Given this list of marker genes CTNNBIP1 (NCBI Gene Id 56998), AMFR, CTHRC1, PRDM15, SOX2, CTDNEP1 (CTD nuclear envelope phosphatase 1), NOTCH1, CCNYL3, FZD10, BAMBI, SULF2, NPHP3, NPHP4, TBL1XR1, DRAXIN, GID8, RNF14, G3BP1, IGFBP6, UBE2B, SOX10, SFRP2, CTNNB1, NFKB1 (nuclear factor kappa B subunit 1), CHD8, PPM1N, MIR212, MIR1260B, DAAM2, LGR4, RBPJ, DKKL1, KPNA1, CCNYL1B, DVL3, FRAT1, TMEM198 (transmembrane protein 198), BMAL1, TLE7 (TLE family member 7), WNT6, MDK, NLE1, STK4, MIR1-1, AXIN2, TCF7L2, SHISA3, FZD7, TLE3, PPP1CA, LRRK2, JUP, RAB5A, CDH3, EDN1, CDK14, SDHAF2, MIR498, PPM1A, RUVBL2, TCF7, DAB2, WNT5A, PYGO1, WNT8A, SOX4, MAPK14, TTC21B, DISC1, WNT9A, TPBGL, VCP (valosin containing protein), SFRP5, EDNRA, WNT7B, TMEM88, APC, DDX3X, RBMS3, USP47, ZNRF3, TRPM4, BCL9L, TBL1X, NKD2, PRKN, GPC3, EGFR, SMAD4, MIR29B1, GPRC5B, GSKIP, MIR29C, CCNYL2, DLX5, FAM53B, BMP2, WNK2, EXT1, HHEX, LZTS2, IFT20, LRRK1, CCNYL1, RNF220 (ring finger protein 220), FZD4, SFRP4, FZD2, KLF4, CSNK1G3, INVS, DAB2IP, CTNND2 (NCBI Gene Id 1501), NDP, EGR1, DACT1, GLI1, NKX2-5, ZEB2, WNT10B, CDH2, CCNY, CSNK1E, SPIN4, MKS1, TLE2, BIRC8, BTRC, HESX1, UBAC2, NR4A2 (NCBI Gene Id 4929), NPPA, SBNO1 (NCBI Gene Id 55241), TLE1, NKD1, DACT3, APOE, FZD3, SCEL, GNAQ, EDNRB, WNT8B, SIAH1, CYLD, CSNK1G1, MIR665, MIR199A1, GREM1, RSPO1, IGFBP1, ASPM, FRZB, NHERF1, FGF2, TMEM88B, CBY1, CAPRIN2, PTPRO, NOG (NCBI Gene Id 9241), FOXD1, HECW1, WNT3A, LRP5, LIMD1, COL1A1, RUVBL1, CSNK1G2, PRICKLE1, FOXO1, WNK1 (WNK lysine deficient protein kinase 1), EGF, WWTR1, EMD, PFDN5, RARG, PPM1B, OTULIN, SFRP1, NOTUM, TCF7L1, FZD8, MIR501, ILK, SHH, SOST (NCBI Gene Id 8149), PTPRU, SOX9, IGFBP2, FZD5, FGF10, AMER3, USP34, TNKS, MCC, CAV1, WNT2B, PTK7, PSEN1, MIR203A, CSNK1A1, DKK4, CCDC88C, SHISA6, SOX13, AXIN1, FRAT2, FOLR1, GATA3, MIR26A1, RSPO3, TGFB1, RSPO4, TMEM196, FUZ, TLE4 (TLE family member 4, transcriptional corepressor), PYGO2, ADGRA2, MIR346, APC2, DVL1, SEMA5A, ADNP, WNT9B, SOSTDC1, FZD9, APP, POU5F1 (NCBI Gene Id 7934), FZD1, SMAD3, AMER1, SRC, TMEM131L (NCBI Gene Id 23240), RSPO2, FZD6, ZNF703, LGR6, PIN1, TLE5 (NCBI Gene Id 166), FRMD8P1, WNT5B, SIAH2, DAPK3, WNT16, WNT10A, GPC5, UBR5, LMBR1L, HDAC1, FERMT1, COL6A1 (collagen type VI alpha 1 chain), WNT1, LEF1, VPS35, USP8, PLEKHA4, IGFBP4, SMAD7 (SMAD family member 7), RPS12, WLS, DKK3, TBX18, MLLT3, EDA, WNT11, FGF9, WNT2, WNT4, LYPD6, FOXO3, SDC1, JRK, TMEM9, CSNK1A1L, LRP4, FRMD8, BICC1, ISL1, TNKS2, CCAR2 (cell cycle and apoptosis regulator 2), YAP1, OTUD5, AMER2, ZBED3, KREMEN1, DKK1, STK3, MIR145, JADE1, DIXDC1, TPBG, DDIT3, TMEM64, LATS1, RBX1, LATS2, MIR19B1, MAD2L2, GLI3, SCYL2, RECK, FGFR2 (NCBI Gene Id 2263), VPS4B, SMURF2, RNF146, STK11, NRARP, CSNK1D (NCBI Gene Id 1453), RYK, GSK3A, BCL9, LGR5, SOX17, WNT7A, LRP6, WNT3, XIAP, PPP2CA, PPP2R3A, KANK1, ATP6AP2, DVL2, TMEM170B, MESP1, ANKRD6, DKK2, SNAI1, TLE6, SNAI2, GSK3B, MIR183, here is a description of the gene set: species: Homo sapiens Human Gene Set: GOBP_CANONICAL_WNT_SIGNALING_PATHWAY A type of Wnt signaling pathway in which Wnt binding to its receptor on the surface of a target cell results in the by propagation of the molecular signals via beta-catenin, and end with a change in transcription of target genes. In this pathway, the activated receptor signals via downstream effectors that result in the inhibition of beta-catenin phosphorylation, thereby preventing degradation of beta-catenin. Stabilized beta-catenin can then accumulate and travel to the nucleus to trigger changes in transcription of target genes.